Given this list of marker genes Ccl8, Zc3h12a, Ccnk, Ptx3 (NCBI Gene Id 99687), Smc5, Ltf, Eif2ak4, Apcs, Smc6, Vapa, Vapb, Prkn, here is a description of the gene set: A process in which a host organism stops, prevents or reduces the frequency, rate or extent of a process being mediated by a virus with which it is infected. studied in species Mus musculus Mouse Gene Set: GOBP_NEGATIVE_REGULATION_BY_HOST_OF_VIRAL_PROCESS